The following is a description of a gene set: species: Homo sapiens The process whose specific outcome is the progression of a dorsal root ganglion over time, from its formation to the mature structure. Human Gene Set: GOBP_DORSAL_ROOT_GANGLION_DEVELOPMENT, and this is the list of marker genes: UNC5C, POU4F2, NRP2, RGS4, TUBB3, NRP1, CTNNB1